The following is a description of a gene set: Human Gene Set: WP_APOPTOSIS_MODULATION_AND_SIGNALING species: Homo sapiens Apoptosis modulation and signaling, and this is the list of marker genes: CASP3, PTPN13, BOK, CFLAR, CDKN2A, BAD, CAPNS1 (calpain small subunit 1), BIRC5, TRAF3, MAPK3, ENDOG, BLK, DFFB, MAP3K5, IRAK1, BAX, BIRC7, FOS, MCL1, BIK, CASP1, CASP2, RIPK1, TNFRSF10D, BIRC3, BAK1, SEPTIN4, DFFA, CASP7, TNFRSF1B, TRADD, TRAF6, TOLLIP, TNFRSF10A, BID, BCL2, CASP6, FASLG, HRK, BCL2L1, JUN, PIDD1, TNFSF10, NFKBIA, BCL2L11, AIFM2, BMF, PTRH2, IL1R1, DAXX, CYCS, XIAP, NFKB1, CRADD, MAP3K14, MAPK8, FAS, CASP8, ADAMTSL4-AS1, TNFRSF25, TNFRSF1A, NAIP, APAF1, BCL2L2, CASP10, IL1R2, BCL2A1, BBC3, BCL2L10, CASP9, BIRC2, TNFRSF6B, CASP4, SMIM40, PRKD1 (protein kinase D1), BNIP3, MIR29B1, AIFM1, MIR29B2, BAG3, DIABLO, TNFRSF10B, MADD, HSPA1A, PEA15, PMAIP1, IKBKB, MYD88, TP53, FADD, HTRA2, TNFRSF10C